The following is a description of a gene set: In this study, we examined differential gene expression in naïve human CD4+ T cells, as well as in effector Th1, Th17-negative and Th17-enriched CD4- T cell subsets. We observed a marked enrichment for increased gene expression in effector CD4+ T cells compared to naive CD4+ among immune-mediated disease oci genes. Within effector T cells, expression of disease-associated genes was increased in Th17-enriched compared to Th17-negative cells. We used microarray to examine the gene expresssion profile and level of human naïve, Th1 and effector T cell subsets. Human Gene Set: GSE32901_NAIVE_VS_TH17_ENRICHED_CD4_TCELL_UP from publication Zhang W, Ferguson J, Ng SM, Hui K, Goh G, Lin A, Esplugues E, Flavell RA, Abraham C, Zhao H, Cho JH (PMID 22715389) studied in species Homo sapiens Genes up-regulated in CD4 naïve versus Th17 enriched., and this is the list of marker genes: EML3, PINK1, MAGEE2, STK38, TRIB2 (NCBI Gene Id 28951), MALAT1, RANBP6, SLC17A8, ATAD2B, B3GALT5, MYH8, AQP11, VIPR1, LDLRAP1, PPM1M, GOLGA1, CCS, GUCY2EP, SELENOP, SAP18 (Sin3A associated protein 18), FAM47E, FBXO33, ST8SIA6, PYHIN1, OTULINL, SLC25A45, NSG2, TMEM18, TENT5C, CNOT4, SLC28A2, CDIPT, MTARC2 (NCBI Gene Id 96692), SFXN2, KLHL21, RFXAP, PRKCQ, ZC3HAV1, CCDC117, GRAP2, DAPL1, FAM78A, ELF2, LEF1, PSIP1, TUT7 (NCBI Gene Id 79670), IL17RA, PNRC2, SRPK1, CALHM6 (NCBI Gene Id 441168), C2orf42, GGPS1, TTPA, KLHL6, FBXO30, LMAN2L, NKX6-3, MYOZ1, WNT9B, SLC39A6, PRKD2, GIMAP6, PPP1R3F, RAB27B, FHOD1, C16orf54, TSC22D3, NLRC3, TECPR1, CACNA1I, SLC35G1 (NCBI Gene Id 159371), SLC15A5, VAPB, NOL4, SLC35C1, MACF1, AMFR, CCNL1, PPM1H, CLK1, CYTIP, GABRP, DEAF1, BTC, LTC4S, CRLF3, NXPE3, LFNG, TMEM119 (transmembrane protein 119), ADGRE5, SELL, ABLIM1, GRAMD1A, EHD3, ETS1, CLK4, FHIP1B, EPM2AIP1, CD96, MEX3B, TBC1D23, SPOPL, CPA3, RIT1, SHD, MATK, IQGAP2, PTPN18, KRIT1, SENP2, TMEM170A, SCAI, CDK5RAP3, MIR16-2, TLR3, TMEM71, KLF4, PARP11, EPO, PARG, CXXC4, CMAHP, USP28, SLC44A4, BCL11B, S1PR1, UGGT2, ADD3, KCNMB3, MIR15B, CPEB1, PECAM1, MMP15, ANKRD7, CNGA1, DRD2, ITGB7, SMC4, LIG4, AMH, MS4A2, LCK, ATP6V0E2, FGD3, RMND5A, SNTB1, AXIN2, DCP1B, PLA2R1, CYP26B1, ADH7, INMT, SCGB3A1, PDE2A